Given this list of marker genes Wnt7b, Aqp11, Nnt, Sod2, Egln1, Ciao3, Hif1a, here is a description of the gene set: A homeostatic process involved in the maintenance of a steady state level of oxygen within a cell. Mouse Gene Set: GOBP_INTRACELLULAR_OXYGEN_HOMEOSTASIS species: Mus musculus